The following is a description of a gene set: from publication Yevshin I, Sharipov R, Kolmykov S, Kondrakhin Y, Kolpakov F (PMID 30445619) Human Gene Set: ZNF169_TARGET_GENES studied in species Homo sapiens Genes containing one or more binding sites for (ZNF169) in their promoter regions (TSS -1000,+100 bp) as identified by GTRD version 20.06 ChIP-seq harmonization., and this is the list of marker genes: TSC22D4, CORO1C, LBX1-AS1, LINC01022, CABIN1, ITGB3BP, TXLNB, DBH-AS1, ZNF790, ZNF10, MIR7-3HG, ASPHD1, CRYZL1, SNRPD2, STAT6, LINC00431, EFHB, BRWD1, ANKRD54, OPTN, ARF3, EFCAB7, MAP1LC3B, FAM168A, PLEKHG3, STX6, CERS5, TRAPPC9, KSR2, BCL7A, LINC01132, FBXO31, PRSS8, ARHGAP24, HAR1A, QPCTL, CDKL5, PTCH1, FCHSD2, RABGAP1L, TYR, CASC3, ITSN1, ATN1